Given this list of marker genes HOXD13, MEOX1, RECQL4, GLI3, VPS35L, BCOR (BCL6 corepressor), SALL1, THOC6, PQBP1, FANCB, WNT7A, POMT1, HSPA9, USP9X, B3GLCT, CD19, SALL4, ICOS, FKTN, GPC4, NAA10, TBX4, WNT3, DCHS1, BRCA1, MYCN, TNFSF12, IRF2BP2, RREB1, PERCC1, EHMT1, GDF6, WASHC5, WDR35, FREM2, TNFRSF13B (NCBI Gene Id 23495), CCNQ, FOXF1, CHRM3, KIF7, MKS1, DACT1, CTNND1, ZIC3, MKKS, TBC1D23, FANCI, CCDC22, MS4A1, FKRP, HIRA, HCCS, CR2, DYNC2H1, TBXT, CD81, HPS6, PIGN, GDF3, CDH1, VANGL1, PALB2, DYNC2I2, TCTN3, GPC3, FANCD2, DPYS, CEP120, UBE2T, SPINT2, FANCF (FA complementation group F), SEC24C, DYNC2I1, ABL1, INTU, TWIST2, POMT2, FGFR2, RSPO2, RAD51, RIPK4, RFWD3, KDM6A, GRIP1, FANCE, NFKB2, WBP4, MED12, KAT6B, FRAS1, KMT2C, MAD2L2, FANCM, AR, PIGO, UFD1, NIPBL, MNX1, NDUFB11, LONP1, PITX2, MID1, LARGE1, XRCC2, EXTL3, FANCC, SIN3A, UBR1, ARVCF, FUZ, ERCC4, FANCL (FA complementation group L), FANCA, FANCG, IFT80, COMT, DPYSL5, GP1BB, JMJD1C, NFKB1, MAMLD1, RAB34, TNRC6B, RNU12, SLX4, AMER1, CDC45, UPB1, EMC1 (NCBI Gene Id 23065), TWIST1, BRIP1, BRCA2, KMT2D, RAD51C, NBN, TNFRSF13C, CHD7, PPP2R3C, CAPN15, TBX3, COX7B, SCAF4, EPCAM, TBX1 (T-box transcription factor 1), EBF3 (NCBI Gene Id 276717), here is a description of the gene set: studied in species Homo sapiens Human Gene Set: HP_ANAL_ATRESIA Anal atresia Congenital absence of the anus, i.e., the opening at the bottom end of the intestinal tract.